The following is a description of a gene set: species: Mus musculus Mouse Gene Set: MIR_292A_3P Genes predicted to be targets of miRBase v22 microRNA mmu_miR_292a_3p in miRDB v6.0 with MirTarget v4 prediction scores > 80 (high confidence targets). from publication Chen Y, Wang X (PMID 31504780), and this is the list of marker genes: Ahcyl1, 2510009E07Rik, Dcun1d3, Arid4a, Synpo2, Slc6a15, Sertad2, Kif5b, Dnajb3, Mat2b, Mrtfb, Zfp367 (NCBI Gene Id 238673), Ppp2r2a, Arhgap26, Tmem38b, Ago1, Myoz2, Cep170, Clock, Ccng2, Casp2, Angel1, Kcnd2 (NCBI Gene Id 97339), Dll1, Lamp5, Prr23a1, Rbl2, Rcan3, Irf4, Rnf216, Oga, Phf1, Bin3, 2010106E10Rik, Nbea, Trmt2a, Zbtb7a, Hp1bp3, Rtn4, Znrf3 (zinc and ring finger 3), E2f2, Scml2, Npas2, Zbtb41, Mef2a, Foxj3, Arhgef12, Tenm2 (NCBI Gene Id 77515), Mtmr4, Caprin2, Osr1, Mob1b, Tfap4, Ifi209, Cxcr4, Nedd4l, Cpeb1, Igsf10, Zfp148, Tnik, Fgf9, Stil (NCBI Gene Id 230631), Zc3h12c, Skida1, Pafah1b2, R3hdm1, Tapt1, Dync1li2, Hipk3, Dixdc1, Ankrd9, Rtn1, Rab5b, Nr4a2, Ssbp1, Ube3c, Rrm2, Dpysl5, Ikzf2, Thsd7a, Suv39h1, Mylk, Nfx1, Zfhx4, Lman2, Slc25a13, Epha7, Kdm1b, Nol4l, Eif5a2, Lratd2, Arhgef28 (NCBI Gene Id 77910), B3galt2, Prdm8, S1pr1, Fat2, Rab5c (RAB5C, member RAS oncogene family), Arid4b (AT-rich interaction domain 4B), Dkk1, Chd5, Vps26a, Myrf, Miga2